The following is a description of a gene set: species: Mus musculus Any apoptotic process in a glomerular visceral epithelial cell. Mouse Gene Set: GOBP_PODOCYTE_APOPTOTIC_PROCESS, and this is the list of marker genes: Ppargc1a, Pla2r1, Pla2g1b, Ednra, Abl1